The following is a description of a gene set: Human Gene Set: GOMF_OXIDOREDUCTASE_ACTIVITY_ACTING_ON_SINGLE_DONORS_WITH_INCORPORATION_OF_MOLECULAR_OXYGEN Catalysis of an oxidation-reduction (redox) reaction in which hydrogen or electrons are transferred from one donor, and molecular oxygen is incorporated into a donor. species: Homo sapiens, and this is the list of marker genes: ALOX15B, CDO1, ALOX12, PTGS1, ETHE1, BCO1, HPDL, ALOX12B, ALOX15, HPD, TDO2, IDO2, IDO1, ADO, RPE65, MIOX, PTGS2, BCO2, ALOX5, ALOXE3, HAAO, HGD, ADI1, PIR